The following is a description of a gene set: studied in species Homo sapiens Abnormal narrowing of the choana (the posterior nasal aperture). Choanal stenosis Human Gene Set: HP_CHOANAL_STENOSIS, and this is the list of marker genes: KMT2D, DCHS1 (NCBI Gene Id 8642), FAM20C, FAT4, PAICS, FRAS1, BUB1, ASXL3, MBTPS2, SCARF2, FGFR3, SOST, ANKH, NFIX, SETBP1, POR, MSL3, CEP55, RECQL4, PTDSS1, POLR1D, AXIN1, POLR1B, SALL4, FGFR2, TXNL4A, PTH1R, FGFR1